The following is a description of a gene set: Human Gene Set: MORF_ARL3 Neighborhood of ARL3 Neighborhood of ARL3 ADP-ribosylation factor-like 3 in the MORF expression compendium species: Homo sapiens, and this is the list of marker genes: DGCR5, S100A5, LTBP4, CACNB1, C1orf216, LPGAT1 (NCBI Gene Id 9926), MSL3, SLC6A11, POU6F2, IPO9, CADM4, MFN1, PLPPR4, BCL2, PHOX2B, PHLDB1, TENM4, PART1, GPR18, BARX2 (BARX homeobox 2), ABCB1, TMEM26, GNPAT, PIGR, GABRB2, ZNF266, NRTN, CD8A, NHEJ1, HTR7, ACKR1 (atypical chemokine receptor 1 (Duffy blood group)), SLC16A5, NOTCH4, MYT1, ZNF133, PHF10, SLC22A6 (NCBI Gene Id 9356), FRYL, DDX52, CYP4F2, SIX6, GCM1, SEZ6L (NCBI Gene Id 23544), COLQ, SLC15A1, SULT2B1, RORB, STK17A (NCBI Gene Id 9263), NRXN1, NEUROD2, NCKIPSD, GPATCH8, ATXN3, SLC18A1, AQP7, SRPK3, KRR1, SMYD5, ZNF202, SKI, POLR1HASP, CCL16, ASB4, BCL2L11, IL13, KRT2, ZBTB14, COL14A1, HOXD4, NPFF, TNFRSF25, RGS7, MAGI1, HTR4, RREB1, KCNA5, MAGEA8, PPP2R5B, KNG1, ERC1, WBP4, AMOT, F2RL3, LGI1, SLC17A3, CEACAM4, NXPE3, COX6A2, ZNF141, KRT86, INA, GPLD1, ELL2, NOS2, FZD5, ADAMTSL3, HTR1B, ART1, FUT6, TMEM11, CDC73, PCM1, DBT, CYP11A1, SYNJ2, MLLT10, GABRA1, ARFGEF2, ABO, AFF2, PRKACA, IVL, POLR2K, MC5R, RB1CC1, ATP6V1B1, CALN1, AMMECR1, TBX19, ELAVL2, FGF18, DNAJC16, TANC2, PPP1R1A, SLC2A1, RUNX2, COL19A1, HTR3A, TBXT, PDE6A, FAS, ADCY3 (NCBI Gene Id 9608), ERCC4, RXRG, SLC33A1, PVR, CRHR1, IQCK, COL8A1 (NCBI Gene Id 57086), BRD4, PAX6, ZP2, SIM2, PDE4D, SLC4A8, POU6F1, EN2, ULK2, GNG4 (G protein subunit gamma 4), OCM, ZNF157, ESR1, SGPL1, DRC3 (NCBI Gene Id 83450), CELA2B, HNF1A, GCA, HCRTR2, RPS6KA5, GJB5, NRP2, PIK3C2A, ERC2-IT1, MAP2, KLRC4, MON2, GRIK1, STAC, ATP10B (NCBI Gene Id 80225), EDIL3, PLEKHB1, TSPAN2, GPR171, ATP8B1, SLC46A3, GUCY2C, SLC4A3, NTNG2, NR1I2, SCAMP1, TBC1D22A, NFIC, FNTB, SULT4A1, NF1, KDR, MSH3, GPR19, IL16, SLC13A2, IFT27, SPA17, PRIM2, MDM2, COLGALT2, OPLAH, PAX7, ATF7, DTNA, TACC2, PDE10A, ATF2, HTR1E, CTRL, MYL3, MSX1, ZSCAN26, OPRL1, POFUT2, GUCY2F, FBXL4, ADAM20, ABCB9 (NCBI Gene Id 23457), BNIP1, KLHL18, CXCL5, NR3C2, ITIH3, TPD52, TFDP2, MAPT, FIG4, PAXIP1, COQ7, RAD51D, NFAT5 (nuclear factor of activated T cells 5), IGKV7-3, HSD3B2, TBX5, MYOZ3, AQP5, CAMK2G, EPHB2, GLE1, TIE1, CYP2A6, FLT1, CFH, ETV3, TRIM24, ZBTB40, GRIK5, CASP10, CEP162, PAX9, SUPT3H, CAMK4, RYR3, CCR3, LY9, BMP10, ZNF33B, SLC6A2, EXOC4, P2RY10, IL11RA, MAGEA9, DOCK1, SERPINA4 (NCBI Gene Id 5267), R3HCC1L, CYP2D6, TSSK2, OR10H3 (NCBI Gene Id 26532), HOXA11, JADE3, SIRPB1, PSG1, SCAPER, DKK4, GRIP2, SYT5, KRT33A, NR2F1, BRCA1, H3C6, ADCYAP1, IGF2, ITIH4 (NCBI Gene Id 3701), ZNF500 (zinc finger protein 500), PRELID3A, AOC4P (NCBI Gene Id 90586), FSHR, JRK, ABCC8, HABP4, OR2B6, JRKL, ARL3, SCN7A, CYP2E1, PTPRB, ABCB10, PIK3CB, DPT, LORICRIN, ATP6V0A2, PGM3, FRY, FOSL1, PPP1R12B, CD6, TRIO, CPB2, UBE4B